Given this list of marker genes Ssrp1, Gm20830, Scml4, Uimc1, Gm20773, Anp32e, Bcas3 (NCBI Gene Id 76344), Gm20737, Hinfp, Grwd1, Ager, Wdtc1, Brd3, Nanog, Phc2, Baz2a, Hjurp, Gm20822, Stat1, Aire, Zcwpw1, Spin2-ps7, Eed, Hira, Ing2, Hoxb5os, Chd6, Gm20816 (NCBI Gene Id 100039810), Tspyl3, Sart3, Msl3, Dpf2, Sirt1, Gm21292, Gk, Gm21854, Zmynd8, Suz12, Lrwd1, Morc4, Wrap53, Mbtd1, Rbbp4, Phf8, Tnks, Npm2, Spin2-ps3, Cbx2 (chromobox 2), Atad2b, Kmt5c, Ctcfl, Tbl1x, Spin2d, Usp16, Uhrf1, Gm20806 (predicted gene, 20806), Cks1b, Cbx8, Rag2, Hdac4, Dppa3, Chd1, Set (SET nuclear oncogene), L3mbtl4, H2ax, Spin2c (spindlin family, member 2C), Hdac2, Taf1, Gm20795, Kdm4a, Dnajc2, Usp3, Sbno2, Nbn, Phip, Fmr1, Npm3, Noc2l, Prmt6, Smarca5, Cd1d2, Spty2d1, Gm20808, Cks2, Daxx, Gm21394 (predicted gene, 21394), H2bc1, Scmh1, Kdm8, Atad2, Yeats2, Baz1b, Gm20747, Spin4, Rbbp7, Rcc1, Mllt1, Chd8, ENSMUSG00000121958, Tspyl1, Gm20815, Mphosph8, Cbx3, Msh6, Prmt7, Smarcc1, Nap1l3, L3mbtl1, Rrp8, Cks1brt, Chd5, Ipo7, Sfmbt1, Morc2a, Fh1, Phf13, Zzz3, Ing4, Pwwp2a (PWWP domain containing 2A), Dtx3l, Kdm5b (lysine demethylase 5B), Cbx1, Gm20738, Ing5, Cbx5, Tbl1xr1, Gm20821, Ptma, Ssty1, Tspyl2, Anp32b, Rag1, Ssty2, Ncl, Phf14, Zmynd11, Pkn1, Vrk1, Hpf1, Mllt3, Smarca2, Jmjd7, Spin2e, Mllt6, Mllt10, Nasp, Gm21719, Gm20812, Anp32-ps, Aplf, Mtf2, Phc1, Gm20825, Ptms, Gm20826, Kdm5a, Nap1l2, Gm21310, Coprs, Hat1, Wdr5, Smarca4, Sgf29, Trp53bp1 (NCBI Gene Id 27223), L3mbtl3, L3mbtl2, Brdt, Mcm3ap, Gm20917, Morc3, Sbno1, Kmt2e, Rnf168, Supt6, Anp32a, Gm20918, Uhrf2, Brd9, Psme4, Ctsl, Glyr1, Trim24, Smarcc2, Spin2-ps2, Samd11, Phf2, Pou5f1, Tonsl, Znhit1 (NCBI Gene Id 70103), Brd4, Hdgfl2, Scml2, Tspyl4, Gm20818, Kdm7a, Chd2, Spin2-ps9, H1f9, Gm21812, Rnf20, Spin2j, Zcwpw2 (NCBI Gene Id 74638), Brd1, Gm20807, Snca, Usp49, Atrx, Rsf1, Vps72 (vacuolar protein sorting 72), Spin2-ps10, Jak2, Sphk2, Phf19, Ncapg2, Nap1l1, Chd4, Bptf, Ing3, Gm21118, Brd7, Kdm1b (NCBI Gene Id 218214), Mcm2, Brd2, Kmt2a, Ing1, Ezh2, Samd7, Yeats4, Cdyl2, Spin2h, Apbb1 (amyloid beta precursor protein binding family B member 1), Spin1, Carm1, Gm20914, Dnajc9, Zfp689, Npm1, Gm28171, Thap7, Gm20873, Pygo2, Ipo9, Sfmbt2, Spin2-ps8, Asf1b, Zzef1, Wdr5b, Ino80, Mysm1, Spin2g, Phc3 (NCBI Gene Id 319628), Pih1d1, Cd1d1, Cdyl, Lef1, Gm20834, Srcap, Gm20854, Cbx6, H2al2a, Rbbp5, Chd7, Spin2-ps4, Prkcb, Spin2-ps1, Asf1a, Gm20865, Ncapd2, Tdrd3, Tspyl5, Phf6, Ezh1, Rnf8, Setd5, Nap1l4, Parp9, Phf1, Ncapd3, Sap30l, Gm20852, Pygo1, Stpg4, Dek, Cxxc1, Usp51, Chd3, here is a description of the gene set: studied in species Mus musculus Mouse Gene Set: GOMF_HISTONE_BINDING Binding to a histone, any of a group of water-soluble proteins found in association with the DNA of eukaryotic or archaeal chromosomes. They are involved in the condensation and coiling of chromosomes during cell division and have also been implicated in gene regulation and DNA replication. They may be chemically modified (methylated, acetlyated and others) to regulate gene transcription.